Given this list of marker genes SOX2, ITGB2 (NCBI Gene Id 3689), LAMC1, TNRC6A, SSBP3 (NCBI Gene Id 55126), LAMA3, SETD2, TGFB1, MAP2K1, SMAD4, MIXL1, SMAD3, CTR9, VTN, GRB2, MMP9, NR0B1, ITGA5, HMGA2, POU5F1, FGF8, DUSP4, MACROH2A1, COL5A2, MMP15, DUSP2, LAMB1, HNF1B, BMPR1A, COL4A2, DKK1, GATA6 (NCBI Gene Id 2627), COL11A1, GDF1, BMP4 (bone morphogenetic protein 4), MESP1, COL8A1, MMP8 (matrix metallopeptidase 8), MYH9, ARC, NKX2-1 (NK2 homeobox 1), CTNNB1, APELA, EOMES, ITGB5, LAMB3, PELO, BPTF (NCBI Gene Id 348241), COL7A1, HOXC11, RTF1, ENSG00000285205, NOTCH1, SOX7, PAF1, NODAL, GDF3 (NCBI Gene Id 9573), HSBP1, HDAC1, LEO1, ONECUT1, ITGA4, EPB41L5, SOX17, EXT1, ITGA7, LHX1, CDC73, INHBA, COL6A1, NOG, ITGAV, NANOG (Nanog homeobox), SMAD2, FN1, DUSP5, NCKAP1, BRD3, COL5A1, MED12, DUSP1, KIF16B, MMP14, GATA4, PAX9, MMP2, TBX20, COL12A1, ZFP36L1, here is a description of the gene set: species: Homo sapiens Human Gene Set: GOBP_ENDODERM_DEVELOPMENT The process whose specific outcome is the progression of the endoderm over time, from its formation to the mature structure. The endoderm is the innermost germ layer that develops into the gastrointestinal tract, the lungs and associated tissues.